The following is a description of a gene set: species: Mus musculus A transposable element silencing mechanism in which mRNAs transcribed from transposons are targeted for degradation. Mouse Gene Set: GOBP_TRANSPOSABLE_ELEMENT_SILENCING_BY_MRNA_DESTABILIZATION, and this is the list of marker genes: Mov10, Piwil4, Tut4, Tut7, Piwil2